Given this list of marker genes MN1, FGF18, COL1A1, AXIN2, GIT1, MMP2, here is a description of the gene set: studied in species Homo sapiens The formation of bone or of a bony substance, or the conversion of fibrous tissue or of cartilage into bone or a bony substance, that does not require the replacement of preexisting tissues. Human Gene Set: GOBP_DIRECT_OSSIFICATION